The following is a description of a gene set: Human Gene Set: HP_HAIR_FOLLICLE_NEOPLASM Hair follicle neoplasm species: Homo sapiens An uncontrolled autonomous cell-proliferation originating in a hair follicle, which is an epidermal adnexal structures responsible for hair growth., and this is the list of marker genes: SEC23B, KLLN, PTEN, GJB2, GJB6